The following is a description of a gene set: Genes negatively differentially expressed in cell type: cDC1 (conventional dendritic cell type 1) upon treatment with cytokine: EGF in mouse lymph nodes in vivo. Mouse Gene Set: CUI_CDC1_EGF_RESPONSE_DN Cytokines mediate cell-cell communication in the immune system and represent important therapeutic targets. A myriad of studies have highlighted their central role in immune function, yet we lack a global view of the cellular responses of each immune cell type to each cytokine. To address this gap, the authors created the Immune Dictionary, a compendium of single-cell transcriptomic profiles of more than 17 immune cell types in response to each of 86 cytokines (>1,400 cytokine-cell type combinations) in mouse lymph nodes in vivo. A cytokine-centric view of the dictionary revealed that most cytokines induce highly cell-type-specific responses. For example, the inflammatory cytokine interleukin-1β induces distinct gene programmes in almost every cell type. A cell-type-centric view of the dictionary identified more than 66 cytokine-driven cellular polarization states across immune cell types, including previously uncharacterized states such as an interleukin-18-induced polyfunctional natural killer cell state. from publication Cui A, Huang T, Li S, Ma A, Pérez JL, Sander C, Keskin DB, Wu CJ, Fraenkel E, Hacohen N (PMID 38057668) species: Mus musculus, and this is the list of marker genes: Clk1, Atf3 (activating transcription factor 3), Parp8, Pmaip1, Rgs1, Fosb, Fos, Nr4a2, Zfp36, Klf4, Nr4a1, Btg1, Ier5, Mpeg1, Kctd12, Klf6 (Kruppel-like transcription factor 6), Jund, Zfp36l1, Klf2, Dusp1